Given this list of marker genes Sumo1, here is a description of the gene set: electronically inferred by orthology from the curated human pathway species: Mus musculus part of: SUMO E3 ligases SUMOylate target proteins Reactome Pathway: SUMOylation of nuclear envelope proteins This event has been computationally inferred from an event that has been demonstrated in another species.<p>The inference is based on the homology mapping from PANTHER. Briefly, reactions for which all involved PhysicalEntities (in input, output and catalyst) have a mapped orthologue/paralogue (for complexes at least 75% of components must have a mapping) are inferred to the other species.